Given this list of marker genes HSPA4, SOCS2, ELMO2, SUMO3, CEBPA, PPIF, MAPK1, ODC1, CORO1A, CDC20, SEC23IP, TIGAR, RPP25, SLC29A1, ABCF2, DNAJA1, QRSL1, RET, STIP1, RNF14, KLC2, TIMM23, POLR3K, KIAA0930, ARPC4, DOLK, AUNIP, BAK1, ALDH4A1, SLC24A3, CYB561, IDH3A, ACOT7, ESR1, CHKA, RNASEH1, DCTN5, DHX29, AREL1, PSEN2, GDPD3, GCH1, PIK3R3, ATP2A3, SRSF1, STX3, ATP6V0A2, RIOX1, NDUFS6, WDR77, HNRNPH1 (heterogeneous nuclear ribonucleoprotein H1), CXCL12, BRMS1, PYCR3, FKBP4, OGDH, FUS, GLYR1, NR2F6, GNA13, CTPS1, CCDC86, ASPSCR1, SCYL2, BOP1, LARP4, RRP15, TAF9B, MAPKAPK2, RAB35, SLCO3A1 (solute carrier organic anion transporter family member 3A1), SLC5A6, TMEM259, PRP4K, SORT1, LARS2, TOMM22 (NCBI Gene Id 56993), EIF5A, ILRUN, TMEM33, AOX1, CA2, ADAT1, OSTM1, GAS2L1 (growth arrest specific 2 like 1), ZMPSTE24, ZWILCH, FASTKD5, CHUK, SOBP, NCLN, CENPN, TFAP2C, ARHGDIA, ETF1, NUP98, URB2, ADGRG1, ADORA1, PSME3, GLUD1, GPS1, SLC7A6, COPA, HSPH1, RANGAP1 (Ran GTPase activating protein 1), GYG1, SLC25A44, NIP7, AMD1, LRRC59, RMC1, SRM, FLAD1, GPATCH2, SNRNP40, SLC35B1, SLC35C1, SPDEF, HHEX, PNO1, SLC52A2, TOR3A, CCND3, HSF1, PDZK1, CORO1B, PUS1, KPNA4, MAZ (NCBI Gene Id 4150), EXOSC4, CALM1, MRPS12, TMEM50B, DDX3X, SRPRA, KPNA1, GULP1, C2CD2, NETO2, EEF1E1, SDF2L1, POLR3E, SPAG1, JAK2 (NCBI Gene Id 3717), IDE, CDV3, here is a description of the gene set: from publication Elvidge GP, Glenny L, Appelhoff RJ, Ratcliffe PJ, Ragoussis J, Gleadle JM (PMID 16565084) studied in species Homo sapiens Human Gene Set: ELVIDGE_HYPOXIA_DN Studies of gene regulation by oxygen have revealed novel signal pathways that regulate the hypoxia-inducible factor (HIF) transcriptional system through post-translational hydroxylation of specific prolyl and asparaginyl residues in HIF-alpha subunits. These oxygen-sensitive modifications are catalyzed by members of the 2-oxoglutarate (2-OG) dioxygenase family (PHD1, PHD2, PHD3, and FIH-1), raising an important question regarding the extent of involvement of these and other enzymes of the same family in directing the global changes in gene expression that are induced by hypoxia. To address this, we compared patterns of gene expression induced by hypoxia and by a nonspecific 2-OG-dependent dioxygenase inhibitor, dimethyloxalylglycine (DMOG), among a set of 22,000 transcripts, by microarray analysis of MCF7 cells. By using short interfering RNA-based suppression of HIF-alpha subunits, we also compared responses that were dependent on, or independent of, the HIF system. Results revealed striking concordance between patterns of gene expression induced by hypoxia and by DMOG, indicating the central involvement of 2-OG-dependent dioxygenases in oxygen-regulated gene expression. Many of these responses were suppressed by short interfering RNAs directed against HIF-1alpha and HIF-2alpha, with HIF-1alpha suppression manifesting substantially greater effects than HIF-2alpha suppression, supporting the importance of HIF pathways. Nevertheless, the definition of genes regulated by both hypoxia and DMOG, but not HIF, distinguished other pathways most likely involving the action of 2-OG-dependent dioxygenases on non-HIF substrates. Genes down-regulated in MCF7 cells (breast cancer) under hypoxia conditions.